Given this list of marker genes SHH, IHH, GATA4, BMP4, FOXF1, here is a description of the gene set: species: Homo sapiens Subsets of mesoderm that have different developmental fates are produced along the primitive streak from posterior to anterior. In mice these subsets are (from posterior to anterior): extraembryonic mesoderm; lateral mesoderm that will form heart, limbs, and blood; presomitic mesoderm that will form somites; axial mesoderm that will form the notochord; and, finally, definitive endoderm. In humans and other primates, extraembryonic mesoderm appears to form from the hypoblast prior to gastrulation so lateral plate mesoderm is the first type of mesoderm to form at the primitive streak.<br>In the lateral plate mesoderm, a self-reinforcing transcription loop is initiated by Hedgehog signaling from the adjacent primitive endoderm (inferred from mouse homologs in Astorga and Carlsson 2007, Becker et al. 1997). Hedgehog proteins SHH and IHH activate expression of FOXF1, a marker of the lateral plate mesoderm following its induction (inferred from mouse homologs in Rojas et al. 2005, Astorga and Carlsson 2007). BMP4 may also activate FOXH1 in the primitive streak and lateral plate mesoderm (inferred from Xenopus homologs in Tseng et al. 2004). FOXF1 activates expression of BMP4 and BMP4 together with FOXF1 activate GATA4 (inferred from mouse homologs in Rojas et al. 2005).. BMP4 maintains the expression of FOXF1. GATA4 maintains its own expression and the expression of BMP4. FOXF1 and GATA4 then activate expression of downstream genes that further differentiate the lateral plate mesoderm. In zebrafish, the combined activity of Eomesodermin, FoxH1, and Mixl1, together with Smad proteins induces lateral plate mesoderm and this mechanism may be shared across chordates. part of: Gastrulation Reactome Pathway: Formation of lateral plate mesoderm